The following is a description of a gene set: species: Homo sapiens A specialized secretory lysosome that is present in cells with cytolytic capability such as cytotoxic T lymphocytes and natural killer cells. Cytolytic granules mediate the storage and regulated excretion of lytic molecules for killing of target cells. Human Gene Set: GOCC_CYTOLYTIC_GRANULE, and this is the list of marker genes: GNLY, STXBP2, RNF19B, LAMP1, KIF5B, GZMH, CALR, ARL8B, TIAL1, SERPINB1, NKG7, SRGN, GZMB, PRF1